The following is a description of a gene set: studied in species Homo sapiens The process in which the 3' end of a pre-tRNA molecule is converted to that of a mature tRNA. Human Gene Set: GOBP_TRNA_3_END_PROCESSING, and this is the list of marker genes: PTCD1, HSD17B10, TRMT10C, TRNT1 (NCBI Gene Id 51095), ELAC1, SSB, ELAC2